Given this list of marker genes SASH3, ARL6IP4, PLPBP, NCKIPSD, RAB33A, CAMSAP1, TMCO1, ELK4, SGMS1, MTOR, SUSD2, MAP2K3, DMRT1, DHX9, JADE1, TBL3, DEGS1, IFT57, CLPP, SLC1A4, MRPL12, EID1, PWP1, DHCR7, RPA1, ZFX, VCL, CEP41, UNG, COL5A1, GALK2, MRPS7, COA3, PRLR (prolactin receptor), IVNS1ABP, LSM3, CEBPZ, LRWD1, OCEL1, ETFB, COLGALT1 (NCBI Gene Id 79709), NOLC1, MKI67, XPO7, DLG1, E4F1, MRPL49, NARF, CCDC120, NGLY1, NMNAT1, SHROOM1 (shroom family member 1), ABL1 (NCBI Gene Id 25), RCAN3 (NCBI Gene Id 11123), PELO, ZNF451, FDFT1, NUDC, GLMN, GATD3, SCN1B, SLC44A1, SPTSSA, LCP1, LSS, TPRG1L, NME6, PDF, NAPG, PTGER2, VPS29, RIC8A, RPS25, ING1 (NCBI Gene Id 3621), SIRT7, MYC (NCBI Gene Id 731404), TUBB6, FAM76A, GASK1B, HMGCR, UPF1, RNF6, ORM1, PHF5A, METTL3, CDC6, PPCDC, PTER, IMPDH2, DYNLL2, LPIN1, MRPL15, HIBADH, TUSC2, PIGP, MED10, LRRC58, SPIC, HES6, CYP24A1, ARAP2, DVL2, FAM118A, TMEM129, MARCHF6, CCDC12, MAFF, SLIT2, RANBP10, SMC2, ZNF598, ARFGAP1, KIFC3, NUMBL, POU1F1, PRKN, CTSA, MCOLN2, SAC3D1, MRPL51, RBM14, EIF4ENIF1 (NCBI Gene Id 56478), ADGRE5, YY1, FTL (ferritin light chain), PTCD2, UBAP2L, DBI, PHKA2, ZFP36L2 (ZFP36 ring finger protein like 2), CDR2, TTYH2, SS18L2, SRP54, HYCC1, UQCC1, KDM5C, UBE2G2, PPP1CC, ALG9, HSPA8, BATF, TIMM8A, ORMDL1, BRIX1, TMEM151B, ANXA3, SRP19, ZNF639, PAIP2, TAOK1, NHERF1, B4GALT1, USP36, ADIPOR2, LTV1, SLC66A2, GRPR, NGEF, H2AX, TOM1, SLC22A5, SLC23A2, FABP4, NTF3, NOP2 (NOP2 nucleolar protein, NCBI Gene Id 4839), ZCCHC17, CD99L2, CHRNA6, TSPAN3, PLEKHA1 (pleckstrin homology domain containing A1), INHA, HOXC13, TRAPPC10, RPRD1A, DDX3Y (NCBI Gene Id 8653), RPA3 (NCBI Gene Id 6119), RDH10, PPP2R3C, TOR4A, IER2, ATF4, G3BP1, SNRNP48, EVI5, PPP4R3B, PARVG, ITGAX, PTGER4, NPM1, UNC119, SQLE, CDPF1, TOR1A, PFDN6, PITPNM2, SHPRH, HDGF, PTBP3, PREP, here is a description of the gene set: Human Gene Set: GSE17721_PAM3CSK4_VS_GADIQUIMOD_6H_BMDC_UP species: Homo sapiens mouse primary BMDCs were stimulated with tlr ligands and gene expression changes were profiled on Affymetrix arrays from publication Amit I, Garber M, Chevrier N, Leite AP, Donner Y, Eisenhaure T, Guttman M, Grenier JK, Li W, Zuk O, Schubert LA, Birditt B, Shay T, Goren A, Zhang X, Smith Z, Deering R, McDonald RC, Cabili M, Bernstein BE, Rinn JL, Meissner A, Root DE, Hacohen N, Regev A (PMID 19729616) Genes up-regulated in comparison of dendritic cells (DC) stimulated with Pam3Csk4 (TLR1/2 agonist) at 6 h versus DC cells stimulated with Gardiquimod (TLR7 agonist) at 6 h.